The following is a description of a gene set: species: Homo sapiens Human Gene Set: HP_INCREASED_CIRCULATING_INTERLEUKIN_6_CONCENTRATION The concentration of interleukin-6 in the blood circulation is above the upper limit of normal. Increased circulating interleukin 6 concentration, and this is the list of marker genes: PLCG1, LYN, PSMB8, PRF1, MEFV, PTPN22, STX11, SASH3, STXBP2, UNC13D, PTPN6, P4HA2, HLA-B, ELF4, PSMB9, IL6R, CBLB (NCBI Gene Id 868), HMOX1, HLA-DRB1